Given this list of marker genes NME5, RSPH4A, RSPH3, DNAJB13, CCDC103, DNAH7, DNAAF2, ODAD3, ARMC2, DNAAF11, NME8, TTC12, ZMYND10, ODAD1 (outer dynein arm docking complex subunit 1), CCDC39, DNAAF1, DNAAF3, SPAG1, DNAAF5, DNAI2, CFAP298, DNAI1, DNAH11, RSPH9, DNAL1, CFAP300, CCDC40 (NCBI Gene Id 55036), DNAH9, here is a description of the gene set: Any structural anomaly of the pseudostratified ciliated epithelium that lines much of the conducting portion of the airway, including part of the nasal cavity and larynx, the trachea, and bronchi. studied in species Homo sapiens Abnormal respiratory epithelium morphology Human Gene Set: HP_ABNORMAL_RESPIRATORY_EPITHELIUM_MORPHOLOGY